The following is a description of a gene set: Genes highly expressed in prenatal hippocampus (cluster 1). from publication Mody M, Cao Y, Cui Z, Tay KY, Shyong A, Shimizu E, Pham K, Schultz P, Welsh D, Tsien JZ (PMID 11438693) Mouse Gene Set: MODY_HIPPOCAMPUS_PRENATAL We have analyzed the developmental molecular programs of the mouse hippocampus, a cortical structure critical for learning and memory, by means of large-scale DNA microarray techniques. Of genes and expressed sequence tags examined, 1,926 showed dynamic changes during hippocampal development from embryonic day 16 to postnatal day 30. Gene-cluster analysis was used to group these genes into 16 distinct clusters with striking patterns that appear to correlate with major developmental hallmarks and cellular events. These include genes involved in neuronal proliferation, differentiation, and synapse formation. A complete list of the transcriptional changes has been compiled into a comprehensive gene profile database (http://BrainGenomics.Princeton.edu), which should prove valuable in advancing our understanding of the molecular and genetic programs underlying both the development and the functions of the mammalian brain. studied in species Mus musculus, and this is the list of marker genes: Rps27, Rpl32l, Rpl19, Pcna, Hnrnpa0, Trp53, Ddx19a, Rpl13, Cks2, Wbp1, H2ax, Eif2s2, Rpl9, Rpl37 (ribosomal protein L37), Cdk2ap1, Lsm4, Ccng2, H2ac6, Rpl13a, Eftud2, Rpl30, Btf3, Rpl8, Polr1c, Ube2c, Eef1g, Gadd45g, Nfyb, Rbpj, H2az2, Cdk4, Gm10275 (NCBI Gene Id 19897), Top2a, Srsf6, Rpl23a, Snrpb2, Rps8, H1f0, Myt1, Rpl34, Neurog2 (neurogenin 2), Ccnd2, Ccnb2, Rps18 (NCBI Gene Id 20084), Eif4a3